The following is a description of a gene set: species: Mus musculus Mouse Gene Set: GOBP_DOUBLE_STRAND_BREAK_REPAIR_VIA_NONHOMOLOGOUS_END_JOINING The repair of a double-strand break in DNA in which the two broken ends are rejoined with little or no sequence complementarity. Information at the DNA ends may be lost due to the modification of broken DNA ends. This term covers instances of separate pathways, called classical (or canonical) and alternative nonhomologous end joining (C-NHEJ and A-NHEJ). These in turn may further branch into sub-pathways, but evidence is still unclear., and this is the list of marker genes: Polb, Kdm2a, Dclre1a, Mrnip, Hmces, Dek, Lig4, Kmt5c, Topbp1, Hmga2, Rif1, Aunip, Nhej1, Polq, Poll, Nudt16l1, Pnkp, Rnf8, Smchd1, Setmar, Nbn, Pot1a, Mad2l2, Mre11a, Parp3, Ercc4, Ercc8, Smarcal1, Kmt5b, Paxx, Prpf19, Trp53bp1, Ercc1, Prkdc, Zbtb7a, Polm, Plk1, Rhno1, Fh1, Dclre1c, Xrcc1, Pot1b, Actr2, Aste1, Mlh1, Kdm4d, Dntt, Lig3, Rnf168, Hsf1, Cyren, Iffo1, Xrcc6, Wrap53, Was, Ercc6, Helq, Dclre1b, Xrcc5, Psmd14, Nsd2, Shld1, Aplf, Xrcc4, Uvrag, Lig1, Shld3, Bend2, Top2b, Usp51, Shld2, Pola1